The following is a description of a gene set: studied in species Homo sapiens Human bone marrow mesenchymal stem cells (hMSCs) give rise to adipocytes in response to adipogenic hormones. An in-house cDNA microarray representing genes was employed to characterize the modulation of genes involved in this process. A total of genes showed temporal gene expression changes during adipogenesis, including genes encoding transcriptional regulators and signaling molecules. Semi-quantitative RT-PCR analyses confirmed differential expression at the transcriptional level of several genes identified by cDNA microarray screening. Cluster analysis of the genes regulated during the late phase (from day 7 to day 14) of hMSC adipogenesis indicated that these changes are well correlated with data previously reported for murine preadipocytes. However, during the early phase (day 1-day 5), the modulations of genes differed from those reported for the preadipocytes. These data provide novel information on the molecular mechanisms required for lineage commitment and maturation accompanying adipogenesis of hMSC. Human Gene Set: NAKAMURA_ADIPOGENESIS_EARLY_UP from publication Nakamura T, Shiojima S, Hirai Y, Iwama T, Tsuruzoe N, Hirasawa A, Katsuma S, Tsujimoto G (PMID 12646203) Genes up-regulated in mesenchymal stem cells during early phase of adipogenesis, defined as days 1 to 5 of culturing with adipogenic hormones., and this is the list of marker genes: WASF3, PDE4D, ZFP36, OXR1, CTNNB1, IL1R1, GAS1, CCRL2, ABL1, GASK1B, COL6A3, NID1, ELK3, SST, MT1B, COL8A1, DKK1, PDE6H, MT1E, ABCA1, MT1M, PRSS23-AS1, PPP1CA, INSIG1, USP4, TGFBR3, IL22RA1, HACD3, MT1F, SOD2, NFIL3, CHMP1B, USP53, MYADM, SMIM3, SIK2, NPTXR, SNAI2, MRPS6, MT1G, FYN, PIK3R1, GM2A (NCBI Gene Id 2760), MYC, LHFPL6, PHKG1, PLIN2, GADD45B, SMARCD2, LIFR, MT1L, IRS2 (insulin receptor substrate 2), E2F4, ACVR2A, FOXO1, FAM174C, MT1H, NFE2, PDE10A, CYBRD1, P3H2, CEBPD, S1PR3